Given this list of marker genes TBXT, FGFR1, SNAI1, EOMES, CLDN7, OCLN, CDH1, here is a description of the gene set: Epithelial-Mesenchymal Transition (EMT) during gastrulation Human Gene Set: REACTOME_EPITHELIAL_MESENCHYMAL_TRANSITION_EMT_DURING_GASTRULATION species: Homo sapiens